The following is a description of a gene set: Mouse Gene Set: GOBP_NEGATIVE_REGULATION_OF_RECEPTOR_MEDIATED_ENDOCYTOSIS Any process that stops, prevents, or reduces the frequency, rate or extent of receptor mediated endocytosis, the uptake of external materials by cells, utilizing receptors to ensure specificity of transport. studied in species Mus musculus, and this is the list of marker genes: Unc119, Lrpap1, Rin3, Dlg4, Lrrtm1, Syt11, Apoc1 (NCBI Gene Id 11812), Adipoq, Picalm, Ankrd13a, Sdcbp, Ankrd13b, Atxn2, Itgb3, Anxa2, Neu3, Apoc2, Abca2, Itgav, Fmr1, Ankrd13d, Sh3gl3, Wdr54, Apoc3, Apoc2l, Lrrtm2, Mtmr2, Ubqln2, Necab2, Rabgef1, Pcsk9